The following is a description of a gene set: studied in species Mus musculus The directed movement of substances into the nucleus. Mouse Gene Set: GOBP_IMPORT_INTO_NUCLEUS, and this is the list of marker genes: Chp1, Tek, Drd1, Akap1, Il6, Mapk14, Heatr3, Nup188, Nup62cl, Pml, Fgf9, Agap3, Ptpn5, Cd36, Shh, Tgfb1, Nup62, Hdac3, Pom121l2, Cdk1, Gper1, Ect2, Ipo7, Fam53b, Nup153, Rasl2-9, Ywhab, Txnip, Bmal1, Hikeshi, Nup85, Akt1, Mapk1, Rpain, Bmpr2, Nutf2, Akirin2, Six2, Nup155, Ipo13, Bag3, Nr4a1, Xbp1 (X-box binding protein 1), Ufm1, Nos3 (NCBI Gene Id 71933), Bmp4, Fermt1, Hnf4a, Cabp1, Lrrk2, Agtr2, Nfatc3, Zc3h12a, Kpna2rt, Nolc1, Sumo1, Cfl1, Ipo4, Rab18, Med1, Jak2, Bmp2, Phip, Cdh1, Hsp90aa1, Ipo5, Fchsd1, Nup35, Angpt1, Dyrk1a, Hsp90ab1, Pttg1ip, Jup, Psen1, Tsc2 (TSC complex subunit 2), Uaca, Spg11, Tnpo1, Notch1, Gli3, Ddx5, Nf1, Akap5, Nup50l, 1700009N14Rik, Pik3r2, Ptgs2, Sec13, Kpna1, Sprn, Traf3ip2, Stat3, Nup50, Prkd1, Nup58, Tmco6, Cdan1, Tnfrsf1a, Prkcq, Bcl3, Ptpn22, Kcnq3, Nup98, Htatip2, Nup54, Lep, Cdkn1a, Dmap1, Nup214, Tnpo2, Hm629797, Elavl1, Pkig, Ranbp2, Syk, Ipo8, Brca1, Ppp3r1, Mavs, Abra, Snupn, Pttg1ip2, Nutf2-ps2, Zic1, Trim28, Tnpo3, Cse1l, Hnrnpa1, Bmpr1a, Fam53a, Pola2, Nup107, Ubr5, Nup88, Ranbp6, Pkia, Hyal2, Gbp4, Kpna7, Cry2, Gckr, Kpna4 (NCBI Gene Id 78766), Pom121, Appl1, Tardbp, Eif4enif1, Ei24, Nutf2-ps1, Adar, Nfkbia, Hcls1, Rab23, Ran, Appl2, Kpna6, Prkag1, Prickle1, Zpr1, Hspa12a, Flna, Stk4, Chp2, Lmna, Sqstm1, Kcnq2, Ipo11, Cwh43, Apod, Hspa8, Efcab7, Ing1, Sirt6, Kpnb1, Tpr, Pik3r1, Ifng, Trp53, Mdfic, Epm2a, Nup93, Kpna3, Ppp3ca, E2f3, Mmp12 (NCBI Gene Id 17381), Agt, Il33, Prkcd, Smo, Bach2, Ipo9, Nup133, Atf2, Rbm22, Kpna2, Phb2, Six3, Stk3, Fam53c, Ep300